Given this list of marker genes Nkx6-2, Nkx6-1, Pax6, Isl1, Hoxd10, Gli2, Sufu (SUFU negative regulator of hedgehog signaling), Gli3, Lhx3, Hoxc10 (homeobox C10), Olig3, Isl2, Mnx1, Lmo4, here is a description of the gene set: Mouse Gene Set: GOBP_SPINAL_CORD_MOTOR_NEURON_CELL_FATE_SPECIFICATION studied in species Mus musculus The process in which a cell becomes capable of differentiating autonomously into a motor neuron in an environment that is neutral with respect to the developmental pathway.